Given this list of marker genes Cyp1a1, Ugt3a2, Ugt3a1, F7, Egfr, here is a description of the gene set: Any process that results in a change in state or activity of a cell or an organism (in terms of movement, secretion, enzyme production, gene expression, etc.) as a result of a hydroxyisoflavone stimulus. Mouse Gene Set: GOBP_RESPONSE_TO_HYDROXYISOFLAVONE species: Mus musculus